The following is a description of a gene set: Any process that activates or increases the frequency, rate, or extent of lymphocyte anergy. studied in species Homo sapiens Human Gene Set: GOBP_POSITIVE_REGULATION_OF_LYMPHOCYTE_ANERGY, and this is the list of marker genes: LILRB4, ITCH, FOXP3, NR5A2, CBLB, CD3E (CD3 epsilon subunit of T-cell receptor complex)